The following is a description of a gene set: studied in species Mus musculus Mouse Gene Set: GOBP_REGULATION_OF_CELLULAR_RESPIRATION Any process that modulates the frequency, rate or extent of cellular respiration, the enzymatic release of energy from organic compounds., and this is the list of marker genes: Trex1, Atp7a, Cbfa2t3, Trpv4, Chchd4 (coiled-coil-helix-coiled-coil-helix domain containing 4), Oas1d, Prdm16, Pik3ca, Oas1c, Vcp, Arl2, Tnf, Pde2a, Ifnlr1, Tefm, Mfn2, Myc, Trap1, Dnajc15, Macroh2a1, Cisd1, Slc25a23, Oas1b, Nupr1, Oas1a, Abcd1, Ide, Ppif, Actn3, Oas1g, Opn3, Park7, Slc25a33, Pink1, Apoc3, Iscu, Tmem135, Ifng, Pnpt1, Uqcc2, Il10rb, Shmt2, Ak4, Mlxipl, Prelid1, Prkaca, Oas1f, Oas1h, Ifnar1, Myog, Nop53, Oas1e, Il4, Akt1, Rhoa